Given this list of marker genes Acadvl, Etfdh, Gcdh (glutaryl-Coenzyme A dehydrogenase), Acad10, Etfb, Ivd, Acad12, Acadl, Etfbkmt, Etfa, Acadm, Acads, Acad11, here is a description of the gene set: Mouse Gene Set: GOBP_FATTY_ACID_BETA_OXIDATION_USING_ACYL_COA_DEHYDROGENASE A fatty acid beta-oxidation pathway in which the initial step of each oxidation cycle, which converts an acyl-CoA to a trans-2-enoyl-CoA, is catalyzed by acyl-CoA dehydrogenase; the electrons removed by oxidation pass through the respiratory chain to oxygen and leave H2O as the product. Fatty acid beta-oxidation begins with the addition of coenzyme A to a fatty acid, and ends when only two or three carbons remain (as acetyl-CoA or propionyl-CoA respectively). studied in species Mus musculus